Given this list of marker genes HLA-DRB1, WIPF1, PTGDR2, PSME2, TIMELESS, FEZ2, MTA1, PLEKHO2, HS1BP3, MMP19, EPSTI1, LAMTOR3, CDT1, TIMP4, MOCOS, FZD4, NXF1, UNG, PFKFB3, DAB2, ITIH3, RASA3, NUMB, EHD4, FAM13B, TCF7L2, PRRX1, TRA2A, BIN3, STX2, TMEM184B, VPS35L, KCTD12, HOXA11-AS, KLHDC4, NEU1, ARNT2, ARRB1, PTTG1, TEX264, CRLF2, EVI2B, NCBP3, TUBB2A, L1CAM, CYSLTR1, TMUB2, ADAM23, IRF2, REEP3, RSPH9, FNDC3A, HDAC7 (histone deacetylase 7), LAMP2, TREM2, CACNB3, IRX5, BCL2L14, RBMS1, CLN8, SH3GLB1, MED24, C1orf54, HACE1, FCGR3A, NSMAF, ZNF524, DPEP3, RFC2, CPT1A, TREX1, USP25, RMDN3, RNPEPL1, CASR, SVEP1, RPL7, JARID2, FNBP4, RND3, BRWD1, GCA, CBX6, KDR, IKZF1, GPR35 (G protein-coupled receptor 35), DSTYK, ZNF395, AVL9, EMP3, SHARPIN, RRM2, NAPSA, SEPTIN8, LAMTOR1, SNRK, TTC3, TXNDC16, ATP6V1B2, PLAAT3, ATP11B, SEC24B, MTMR6, TNFRSF11A, BASP1, SUDS3, BID, TEX14, DOLPP1, LAT2, RPS19, PSME1, UBE2R2, C3AR1, PYY, CLEC4A, ZNF841, SUB1, FGF13, NKX2-2, SELENOT, TLE4, VPS37C, VRK3, ERLIN1, AHCYL1, CYTH1, RPL38, CXCL10, MTMR10, DOK3, DPYS, KIF2A, CSK, ARL4C (ADP ribosylation factor like GTPase 4C), RB1CC1, RBKS, PGLYRP1, CD200R1, GPSM3, EPC1, MNT, BATF3, IQGAP1, KATNA1, GPX1, HHEX, ERCC6L, PLIN2, PLCB2, CD68, S100A1, SIRT1, TNFRSF1A, HELZ2, HIVEP1, SLC16A6, IFITM3, MAU2, CD93, STAB1, SLFN12, PAG1, RAP2C, SESN2, MYO9B (myosin IXB), WDR90, TBK1, SLC25A45, SFXN2, KLHL10, C11orf91, ADA, CTDSP2, PTBP3, HERC1, DCT, SPINT2, CXCR4, RBCK1 (RANBP2-type and C3HC4-type zinc finger containing 1), PRIMA1, MICU1, EGR2, ALDH1B1, GCNT3, HBA2, ITPRID2, VIT, ADAM11, TOM1, KAT2B, CNR2, PACS2 (NCBI Gene Id 23241), CAPG, RPL28, IDS, C19orf48P, GIGYF1, MICOS13, here is a description of the gene set: mouse primary BMDCs were stimulated with tlr ligands and gene expression changes were profiled on Affymetrix arrays Genes down-regulated in comparison of dendritic cells (DC) stimulated with LPS (TLR4 agonist) at 24 h versus DC cells stimulated with poly(I:C) (TLR3 agonist) at 24 h. from publication Amit I, Garber M, Chevrier N, Leite AP, Donner Y, Eisenhaure T, Guttman M, Grenier JK, Li W, Zuk O, Schubert LA, Birditt B, Shay T, Goren A, Zhang X, Smith Z, Deering R, McDonald RC, Cabili M, Bernstein BE, Rinn JL, Meissner A, Root DE, Hacohen N, Regev A (PMID 19729616) Human Gene Set: GSE17721_LPS_VS_POLYIC_24H_BMDC_DN species: Homo sapiens